Given this list of marker genes Htt, Kdelr1, Rab4b, Scyl1 (NCBI Gene Id 98159), Scfd1, Rab10, Arf3, Rab13, Vamp5, Prkd1, Tmed3 (NCBI Gene Id 66111), Tmed11, Nbas, Spire2, Golph3, Prkci, Cux1, Kif13a, Mapk15, Exoc5, Tmed5, Exoc4, Golga5, Exoc1, Uso1, Bet1, Gosr1, Rab6a, Tex261, Stxbp5, Ap3s1, Tbc1d14, Rabep1, Zw10, Arf5, Eps15, Cog5, Whamm (NCBI Gene Id 434204), Sec24b (NCBI Gene Id 99683), Exoc6b, Rab1b, Arfrp1, Vamp3, Rab11fip3, Acsl3, Cog3, Mia3, Sec31b, Arl1, Macf1 (microtubule-actin crosslinking factor 1), Kif16b, Arf1, Bcap31, Tmed1, Rabggta, Golga7, Rab14, Ccdc91, Trappc12, Ankfy1, Kdelr2, Sec16b, Cog4, Vapb, Spast, Golt1a, Creb3l2, Snx2, Gbf1 (NCBI Gene Id 73518), Pdcd6, Tmed7, Ykt6, Sec22b, Hyou1, Trappc1, Rufy1, Vamp4 (vesicle-associated membrane protein 4), Bltp3b, Ergic3, Cyth3, Snx8, Lrrk2, Vps54, Cog7, Sorl1, Gga1, Bcap29, Yipf4, Csk, Uvrag, Trappc11, Pkdcc, Ero1b (endoplasmic reticulum oxidoreductase 1 beta), Blzf1, Coro7, Ank3, Sgsm2, Mia2, Golga2, Vps29, Lypla1, Copz1, Yif1b, Nsf, Ap3s2, Sort1, Arf4 (ADP-ribosylation factor 4), Ier3ip1, Vps51, Plcb3, Vapa, Atp2c1, Sec16a, Sec24d, Ergic2, Rangrf, Rab33b, Lyplal1, Bnip1 (NCBI Gene Id 76517), Copg2, Snx3, Exoc8, Sec22c, Tmed10-ps, Mppe1, Vti1b, Klhl20, Rbsn, Cnst, Trip11, Chic2, Ergic1, Commd1, Myo1b, Tmed6, Ank1, Sec23a, Bbs2, Gga2, Rabggtb, Rab7b, Scap, Sec22a, Cog2, Rint1, Nrbp1, Gcc2, Snx12, Optn, Gak (NCBI Gene Id 231580), Arfgef2, Kdelr3, Vps35l, Ap1g1, Stx6 (syntaxin 6), Lamp1, Arl8b, Cnih4, Bicd2, Lman1l, Tmed4, Copa (NCBI Gene Id 98590), Trappc2, Stx17, Trappc4, Copz2, Slc10a7, Rab34, Sorcs1, Phaf1, Erp29, Ap3d1, Arfgap3, Vps52, Gas1, Yif1a, Golph3l, Trappc5, Tmed2, Wipi1, Cog6, Vti1a, Trappc2b, Dipk2a, Pgap1, Trappc3, Cep19, Dop1a, Trappc6a, Atp9b, Trappc6b, Spire1, Cog8, Cideb, Tbc1d20, Rnf139, Mon2, Arfgap2, Ehd3, Trappc3l, Prepl, Nbea, Snx1, P4hb, Dop1b, Lman1, Trappc9, Rab6b, Sec23b, Copb2, Llgl1, Vamp2, Trappc2l, Gosr2, Yipf7, Copg1, Myo18a, Stxbp5l, Tmed9, Plpp3, Sptbn1, Stx5a (syntaxin 5A), Sec31a, Exoc2, Cope, Nkd2, Cln3, Bbs1, Preb, Trappc13, Slc30a6, Sec13, Use1, Arl3, Golga4, Rack1, Rabif, Ap4m1, Ccdc22, Ccdc93, Dnm2, Arcn1, Rp2, Gga3, Atp9a, Klhl12, Surf4, Insig1, Cul3, Pitpnb, Rab31, Tmem115, Golt1b, Lman2, Yipf5, Gabarapl2, Sec24c, Myo5a, Steep1, Rab1a, Tmed10, Stx18, Copb1, Bet1l, Amn, Steap2, Yipf6, Sar1a, Cog1, Rab26, Lman2l, Sec24a, Kif1c, Rab8a, Ap1g2, Exoc6, Vcp, Krt18, Sar1b, Llgl2, Ap1ar, Laptm5, Trappc10, Pef1, Ap5z1, Tfg, Vps41, Lmf1, Rer1, Sys1 (SYS1 Golgi-localized integral membrane protein homolog (S. cerevisiae)), here is a description of the gene set: studied in species Mus musculus Mouse Gene Set: GOBP_GOLGI_VESICLE_TRANSPORT The directed movement of substances into, out of or within the Golgi apparatus, mediated by vesicles.